The following is a description of a gene set: Reactome Pathway: Synthesis of bile acids and bile salts part of: Bile acid and bile salt metabolism In a healthy adult human, about 500 mg of cholesterol is converted to bile salts daily. The major pathway for bile salt synthesis in the liver begins with the conversion of cholesterol to 7alpha-hydroxycholesterol. Bile salt synthesis can also begin with the synthesis of an oxysterol - 24-hydroxycholesterol or 27-hydroxycholesterol. In the body, the initial steps of these two pathways occur in extrahepatic tissues, generating intermediates that are transported to the liver and converted to bile salts via the 7alpha-hydroxycholesterol pathway. These extrahepatic pathways contribute little to the total synthesis of bile salts, but are thought to play important roles in cholesterol homeostasis. species: Homo sapiens, and this is the list of marker genes: AKR1D1, SLC27A2, CYP7A1, CYP7B1, AKR1C3, OSBP, ABCB11, AMACR, HSD17B4 (hydroxysteroid 17-beta dehydrogenase 4), AKR1C1, CYP39A1, OSBPL9, AKR1C2, OSBPL2, NCOA2, RXRA, OSBPL6, CYP27A1, OSBPL3, SLC27A5, CH25H, OSBPL1A (NCBI Gene Id 55097), HSD3B7, OSBPL7, NCOA1, ACOX2, SCP2, CYP8B1, BAAT, CYP46A1, ACOT8, NR1H4, AKR1C4